Given this list of marker genes SMAD2, DLX5, WNT3A, TBX6, PSMB1, TRIM33, ZIC2, PSMC5, TFAP2A, PSMB7, NOTCH1, FOXA2, TBPL2, FOXA1, PSMD11, ZEB2, PSMB4 (proteasome 20S subunit beta 4), SOX2, RIPPLY2, MYB, PAX6, MSGN1, FGF4, ZIC1, PSMC1, PSMD14, TEAD4, POU3F1, MESP2, SOX1 (SRY-box transcription factor 1), NOG, RBPJ, MAMLD1, PSMD2, PSMA1, MSX1, TFAP2B, GATA6-AS1, PSMC6, MAML1 (mastermind like transcriptional coactivator 1), PSMC3, EPHA4, PSMA6, ZNF521, SHH, PAX7, GATA6, ADRM1, GBX2, PSMA7, PAX3, PSMC2, BMP4, LEF1, EOMES, FOXF1, PSMD1, KAT2A, HES7, PSMC4, OTX2, CDH1, PSMB5, YAP1, OSR1, TCF7, SEM1, LFNG, PSMD12, FGFR1, FOXH1, EP300, FOXC2, TBXT, PAX2 (paired box 2), CTNNB1, IHH, NANOG, OCLN (occludin), PSMD6, LINC00261, MAML3, DLL3, PSMB6, PSMB3, PSMB2, CXCR4, SNAI1, MIXL1, CREBBP, KAT2B, LHX1 (LIM homeobox 1), TFAP2C, SMAD3, POU5F1, SNW1, MAML2, TCF7L1, SOX17, TEAD2, TCF7L2, CLDN7, PSMD7, PSMA5, GATA4, DLL1, FOXC1, PSMA2, FGF8, PSMD13, GSC, NOTO, PSMA4, SMAD4, PSMA3, PSMD3, FGF2, PSMD8, PAX8, here is a description of the gene set: species: Homo sapiens Human Gene Set: REACTOME_GASTRULATION Gastrulation